Given this list of marker genes Scgb2b27, Rap1gap, Dhrs7, Tesc, Spdef (SAM pointed domain containing ets transcription factor), Atp1b1, Pik3ap1, Acss1, Bcl2l14, Bckdha, 2310057J18Rik, Dhrs4, Rassf3, Slc31a2, Lig3, Car6, Abcb6, Hdac11, Lrrc26, Smpdl3a, Abhd11os, Tspan8, Gne, Mansc1, H2-Q2, Ppargc1a, 1500002F19Rik, Mfsd4a, Cpd, Nr4a1, Ncald, Gjb1, Aass, Fam234b, Iqgap2, Tpd52l1, Cldn2, Chn2, Creb3l4, Elapor1, Ddo, Tspan13, Ggnbp1, Sidt1, Homer2, Upb1, Bhlha15, Slc7a4, here is a description of the gene set: Human breast cancer has been characterized by extensive transcriptional heterogeneity, with dominant patterns reflected in the intrinsic subtypes. Mouse models of breast cancer also have heterogeneous transcriptomes and we noted that specific histological subtypes were associated with particular subsets. We hypothesized that unique sets of genes define each tumor histological type across mouse models of breast cancer. Using mouse models that contained both gene expression data and expert pathologist classification of tumor histology on a sample by sample basis, we predicted and validated gene expression signatures for Papillary, EMT, Microacinar and other histological subtypes. These signatures predict known histological events across murine breast cancer models and identify counterparts of mouse mammary tumor types in subtypes of human breast cancer. Importantly, the EMT, Adenomyoepithelial, and Solid signatures were predictive of clinical events in human breast cancer. In addition, a pan-cancer comparison revealed that the histological signatures were active in a variety of human cancers such as lung, oral, and esophageal squamous tumors. Finally, the differentiation status and transcriptional activity implicit within these signatures was identified. These data reveal that within tumor histology groups are unique gene expression profiles of differentiation and pathway activity that stretch well beyond the transgenic initiating events and that have clear applicability to human cancers. As a result, our work provides a predictive resource and insights into possible mechanisms that govern tumor heterogeneity. from publication Hollern DP, Swiatnicki MR, Andrechek ER (PMID 29346386) Genes that have high expression in mammary tumors of microacinar histology. studied in species Mus musculus Mouse Gene Set: HOLLERN_MICROACINAR_BREAST_TUMOR_UP